Given this list of marker genes Defa30, Defa32, Defa41, Defa39, Defa24, Defa17, Defa35, Defa38, Defa23, Art1, Defa31, Prss2, Defa3, Defa26, Prss3, Defa25, Defa42, Defa37, Defa43, Defa34, Defa28, Defa36, Defa20, Defa21, Try10, here is a description of the gene set: Reactome Pathway: Alpha-defensins part of: Defensins species: Mus musculus This event has been computationally inferred from an event that has been demonstrated in another species.<p>The inference is based on the homology mapping from PANTHER. Briefly, reactions for which all involved PhysicalEntities (in input, output and catalyst) have a mapped orthologue/paralogue (for complexes at least 75% of components must have a mapping) are inferred to the other species. electronically inferred by orthology from the curated human pathway